The following is a description of a gene set: species: Homo sapiens An abnormally elevated concentration of total tryptase (alpha and beta tryptase) in the blood circulation. Human Gene Set: HP_ELEVATED_TOTAL_SERUM_TRYPTASE Elevated total serum tryptase, and this is the list of marker genes: KIT, SRSF2, RUNX1, TET2, CBL, ASXL1